Given this list of marker genes CGA, HSD3B1, SRD5A1, HSD17B12, LHB, SRD5A3, HSD17B3, POMC, CYP17A1, HSD3B2, SRD5A2, here is a description of the gene set: species: Homo sapiens Human Gene Set: REACTOME_ANDROGEN_BIOSYNTHESIS Androgen biosynthesis